The following is a description of a gene set: Human Gene Set: KEGG_MEDICUS_REFERENCE_ANXA2_S100A10_REGULATED_ACTIN_CYTOSKELETON ANXA2-S100A10-regulated actin cytoskeleton. Pathway ID: N01304. Pathway type: Reference. Pathway class: nt06135 Cytoskeletal regulation (viruses and bacteria). Pathway Definition from KEGG: (ANXA2+S100A10) == AHNAK == (ACTB,ACTG1) studied in species Homo sapiens, and this is the list of marker genes: ANXA2, S100A10 (NCBI Gene Id 6281), AHNAK, ACTB, ACTG1